Given this list of marker genes TP53INP1, ZMAT3, PMAIP1, CCNG1, PERP, here is a description of the gene set: Human Gene Set: JONES_TCOF1_TARGETS species: Mus musculus Treacher Collins syndrome (TCS) is a congenital disorder of craniofacial development arising from mutations in TCOF1, which encodes the nucleolar phosphoprotein Treacle. Haploinsufficiency of Tcof1 perturbs mature ribosome biogenesis, resulting in stabilization of p53 and the cyclin G1-mediated cell-cycle arrest that underpins the specificity of neuroepithelial apoptosis and neural crest cell hypoplasia characteristic of TCS. Here we show that inhibition of p53 prevents cyclin G1-driven apoptotic elimination of neural crest cells while rescuing the craniofacial abnormalities associated with mutations in Tcof1 and extending life span. These improvements, however, occur independently of the effects on ribosome biogenesis; thus suggesting that it is p53-dependent neuroepithelial apoptosis that is the primary mechanism underlying the pathogenesis of TCS. Our work further implies that neuroepithelial and neural crest cells are particularly sensitive to cellular stress during embryogenesis and that suppression of p53 function provides an attractive avenue for possible clinical prevention of TCS craniofacial birth defects and possibly those of other neurocristopathies. Genes up-regulated in E8.5 embryos with heterozygous knockout of TCOF1 compared to wild type. from publication Jones NC, Lynn ML, Gaudenz K, Sakai D, Aoto K, Rey JP, Glynn EF, Ellington L, Du C, Dixon J, Dixon MJ, Trainor PA (PMID 18246078)